The following is a description of a gene set: Human Gene Set: TAKAYAMA_BOUND_BY_AR from publication Takayama K, Kaneshiro K, Tsutsumi S, Horie-Inoue K, Ikeda K, Urano T, Ijichi N, Ouchi Y, Shirahige K, Aburatani H, Inoue S (PMID 17297473) studied in species Homo sapiens The androgen receptor (AR) plays a key role as a transcriptional factor in prostate development and carcinogenesis. Identification of androgen-regulated genes is essential to elucidate the AR pathophysiology in prostate cancer. Here, we identified androgen target genes that are directly regulated by AR in LNCaP cells, by combining chromatin immunoprecipitation (ChIP) with tiling microarrays (ChIP-chip). ChIP-enriched or control DNAs from the cells treated with R1881 were hybridized with the ENCODE array, in which a set of regions representing approximately 1% of the whole genome. We chose 10 bona fide AR-binding sites (ARBSs) (P<1e-5) and validated their significant AR recruitment ligand dependently. Eight upregulated genes by R1881 were identified in the vicinity of the ARBSs. Among the upregulated genes, we focused on UGT1A and CDH2 as AR target genes, because the ARBSs close to these genes (in UGT1A distal promoter and CDH2 intron 1) were most significantly associated with acetylated histone H3/H4, RNA polymerase II and p160 family co-activators. Luciferase reporter constructs including those two ARBSs exhibited ligand-dependent transcriptional regulator/enhancer activities. The present study would be powerful to extend our knowledge of the diversity of androgen genetic network and steroid action in prostate cancer cells. Genes whose promoters bound AR in LNCaP cells (prostate cancer) after exposure to the synthetic androgen R1881, based on ChIP-chip analysis., and this is the list of marker genes: STEAP2, CDK14, MET, TES, CATSPER2, PGC, UGT1A1, CDH2, PPIP5K1, SKAP2